The following is a description of a gene set: Mouse Gene Set: GOCC_U6_SNRNP species: Mus musculus A ribonucleoprotein complex that contains small nuclear RNA U6, the Lsm2-8 heptameric ring complex, as well as several proteins that are unique to the U6 snRNP, most of which remain associated with the U6 snRNA both while the U6 snRNP is free or assembled into the U4/U6 snRNP or into a series of spliceosomal complexes., and this is the list of marker genes: Lsm2, Lsm6, Lsm5, Ddx39b, Lsm4, Lsm3, Lsm8, Lsm7